Given this list of marker genes PPP2CA, BANF1, PPP2R1A, LEMD2, VRK1, KPNB1, LBR, LMNA, CCNB1, TMPO, LMNB1, CCNB2, VRK2, ANKLE2, CDK1, EMD, PPP2R2A, SIRT2, LEMD3, here is a description of the gene set: species: Homo sapiens Reassembly of the nuclear envelope (NE) is initiated at late anaphase/early telophase when BANF1 (BAF), which is dispersed throughout the cytoplasm during metaphase, accumulates on the surfaces of coalesced chromosomes. This is coordinated with the chromatin association of membranes and inner nuclear membrane proteins that include EMD (emerin), TMPO (LAP2beta), LEMD3 (MAN1) and LEMD2 (LEM2), and lamins. The DNA-cross-bridging activity of BANF1 is required for individual chromosomes to properly coalesce for enclosure in a single nucleus. Reactome Pathway: Initiation of Nuclear Envelope (NE) Reformation part of: Nuclear Envelope (NE) Reassembly